The following is a description of a gene set: The series of molecular signals initiated by the binding of a ligand from another organism to a cytoplasmic pattern recognition receptor (PRR). PRRs bind pathogen-associated molecular pattern (PAMPs), structures conserved among microbial species. studied in species Mus musculus Mouse Gene Set: GOBP_CYTOPLASMIC_PATTERN_RECOGNITION_RECEPTOR_SIGNALING_PATHWAY, and this is the list of marker genes: Trim25, Oas1f, Gramd4, Fbxl2, Treml4, C1qbp, Zdhhc3, Aurkb, Tlr8, Erbin, Nlrp1a, Zdhhc5, Tirap, Cd36 (NCBI Gene Id 12491), Brcc3dc, Usp15, Rnf135, Gbp5, Scimp, Clpb, Pycard, Smpdl3a, Sirt2, Gm12250, Lsm14a, Havcr2, Tkfc, Cgas, Traf3ip3, Becn1, Hcfc2, Zcchc3, Washc4, Rab7b, Tasl (TLR adaptor interacting with endolysosomal SLC15A4), Ptpn22, Mapk8, Nlrp3, Trex1, Akt1, Pcbp2, Ptprs, Sec14l1, Zdhhc18, Ripk2, Rigi, Lats1, Ipo5, Ogt, Inava, Oas1a, Slc15a3, Nod2, Src, Map3k7, Rnf170, Ticam1, Irf7, Tbk1, Trim15, Znrf4, Lamp2, Dhx33, Parp1, Ifi208, Slc19a1, Irf3, Ifi209, Oas3, Xiap, Ddx3x, Prkdc, Tnip2, Hspa8, Tnfaip3, Gm15441, Ywhae, Rnf34, Eif2ak2, Tab1, Slc15a4, Zc3hav1, Zdhhc1, Spsb3, Ifi207, Lacc1, Gbp2, Elp6, Peli3, Ufd1, Cptp, Atat1, Trim11, Peli1, Pik3ap1, Tarbp2, Rftn1, Cav1, Trem2, Colec12, Tlr6, Mefv, Nagk, Cd86, Rela, Slc15a2, Ifih1, Irf2, Casp4, Nod1, Ankrd17, Oasl1, Zdhhc12, Alpk1, Brcc3, Trim31, Tax1bp1, Nploc4, Ifi214, Kcnj8 (potassium inwardly-rectifying channel, subfamily J, member 8), Banf1, Mark4, Irgm1, Traf6, Gkn2, F2rl1, Oas1d, Nop53, Aars2, Dhx58, Flot1, Zdhhc9, Phb1, Lyplal1, Slc46a2, Plcg2, Usp17le, Irgm2, Tlr13, Prkd1, Wdfy1, Rtn4, Tlr9, Pum1, Nlrc3, Abhd17a, Hmgb1, Ifi213, Ubqln1, Rsad2, Irf1, Stmp1, Nfkbia, Oas1h, Tlr3, Hspa1b, Unc93b1, Ppt1, Mndal, Csnk1a1, Trim3, D1Pas1, Oas1g, Epg5, Nlrx1, Myd88, Nlrp6, Lats2 (NCBI Gene Id 50523), Kcnk13, Oas1b (2'-5' oligoadenylate synthetase 1B), Sting1, Gpatch3, Ifi203, Ppp6c, Nlrp1b, P2rx7, Cd300ld3, Trim30a (NCBI Gene Id 20128), Tlr4, Ddx60, Ifi206, Nek7, Otulin (NCBI Gene Id 97965), Tlr7, Tifa, Oas1e, Oas1c, Rnf125, Mavs, Ppp2ca, Tnf, Phb2, Riok3, Pum2, Ifi203-ps, Tspan6, Usp50, Btk, Igtp, Nr1h4, Itch